Given this list of marker genes BPGM, KLF3, CROCCP2, CDC27, HBD, BTG2, SLC30A10, LMO2, SPTA1, RNF19A, ANK1, HBZ, SLC30A1, BLVRA, FOXJ2, ARHGEF12, USP15, GYPC, GYPE, ADD2, LRP10, CTSE, VEZF1, TMCC2, RCL1, KDM7A, XK, DMTN, GDE1, LAMP2, PC, BTRC, BSG, HBQ1, ACSL6, PSMD9, AQP3 (aquaporin 3 (Gill blood group)), OSBP2, H1-0, CA1, ADD1, PDZK1IP1, TFRC, FOXO3, BCAM, E2F2, TAL1, DAAM1 (dishevelled associated activator of morphogenesis 1), FECH, HBB, NEK7, SLC4A1, SLC2A1, TSPAN5, CDR2, MAP2K3, TYR, UROS, FN3K, SLC22A4, EPOR, SDCBP, NUDT4, SLC11A2, KLF1, ISCA1, ELL2, PPOX, TMEM9B, BLVRB, CIR1, SMOX, MARCHF2, SELENBP1, CLIC2 (NCBI Gene Id 1193), MFHAS1, NR3C1, KEL, CTNS, SPTB, PRDX2, CCDC28A, NCOA4, MXI1, CAST, RAP1GAP, RBM5, RAD23A (NCBI Gene Id 5886), GCLC, HTATIP2, MOSPD1, SLC25A37, TRIM10, ARL2BP, CPOX, DCUN1D1, TRAK2, SLC66A2, MKRN1, GAPVD1, MOCOS, TCEA1, MARCHF8, SLC6A9, DCAF10, ALDH6A1, DCAF11, CTSB (NCBI Gene Id 3896), BNIP3L, ATG4A, ENDOD1, H4C3, BMP2K, MBOAT2, GLRX5, CA2, ICAM4, YPEL5, OPTN, ALAD, RHCE, RBM38, EZH1, P4HA2, TRIM58, TFDP2, SEC14L1, NFE2L1, MYL4, FTCD, SNCA, C3, MARK3, ABCB6, SLC25A38, HTRA2, RHAG, FBXO34, GYPA, IGSF3, GCLM, RIOK3, TNS1, RNF123, KHNYN, TSPO2, HMBS, NARF, ATP6V0A1, NFE2, RHD, SLC6A8 (solute carrier family 6 member 8), MGST3, KAT2B, UBAC1, HDGF, PIGQ, PGLS (NCBI Gene Id 25796), ALAS2, MPP1, ADIPOR1, EPB41, GMPS, ALDH1L1 (NCBI Gene Id 10840), LPIN2 (NCBI Gene Id 9663), SIDT2, AHSP, PICALM, CCND3, GATA1, HEBP1, TOP1, TENT5C, XPO7, CAT, ERMAP, HAGH, BACH1, SLC7A11, RANBP10, AGPAT4, GYPB, UROD, MINPP1, CLCN3, ACKR1, EIF2AK1, ASNS, HBBP1, TNRC6B, FBXO7, UCP2, ACP5, SYNJ1, ABCG2, EPB42, FBXO9, NNT, SLC10A3, PPP2R5B (protein phosphatase 2 regulatory subunit B'beta), here is a description of the gene set: from publication Liberzon A, Birger C, Thorvaldsdóttir H, Ghandi M, Mesirov JP, Tamayo P (PMID 26771021) Human Gene Set: HALLMARK_HEME_METABOLISM species: Homo sapiens Genes involved in metabolism of heme (a cofactor consisting of iron and porphyrin) and erythroblast differentiation.